Given this list of marker genes Celf1, Zdhhc19, Eppk1, Sorl1, Pdcl3, here is a description of the gene set: studied in species Mus musculus The perinucleolar compartment (PNC) is a subnuclear structure associated with, but structurally distinct from, the nucleolus. The PNC contains large amounts of the heterogeneous nuclear ribonucleoprotein complex (hnRNP) called hnRNP 1 (PTB). Many RNA binding proteins as well as RNA polymerase III transcripts are highly enriched in this compartment. PTB and pol III transcripts are required for the integrity of the PNC. Mouse Gene Set: GOCC_PERINUCLEOLAR_COMPARTMENT